Given this list of marker genes INPP5E, PIK3R4, ARF1, VAC14, ARF3, OCRL, FIG4, PIKFYVE, PIK3C2G, PI4KB, TPTE, PI4KA, PIK3C3, TPTE2, PIK3C2A, PI4K2B, SACM1L, PI4K2A, here is a description of the gene set: studied in species Homo sapiens part of: PI Metabolism At the Golgi membrane, phosphatidylinositol 4-phosphate (PI4P) is primarily generated from phosphorylation of phosphatidylinositol (PI). Other phosphoinositides are also generated by the action of various kinases and phosphatases such as: phosphatidylinositol 3-phosphate (PI3P), phosphatidylinositol 3,4-bisphosphate (PI(3,4)P2), phosphatidylinositol 3,5-bisphosphate (PI(3,5)P2). Reactome Pathway: Synthesis of PIPs at the Golgi membrane